Given this list of marker genes MET, AQP5, EGF, HGF, AQP3, EXOC4, STX4, CTNND1, NECTIN2, CYFIP2, CAMSAP3, EFNA1, EXOC3, EGFR, CDH1 (NCBI Gene Id 999), MYL2, NCKAP1, ABI1, MGAT3, RHOA, AFDN, EPHA2, ARF6, ENAH, NCK1, LPP (LIM domain containing preferred translocation partner in lipoma), ACTN1, DIAPH1, CTNNB1, KIFC3, VCL, PIP5K1C, IGF1R, VASP, MYO6, GIT1, ZYX, ROCK1, CTNNA1, LIMA1, PLEKHA7, here is a description of the gene set: from publication Schaefer CF, Anthony K, Krupa S, Buchoff J, Day M, Hannay T, Buetow KH (PMID 18832364) Human Gene Set: PID_ECADHERIN_STABILIZATION_PATHWAY studied in species Homo sapiens Stabilization and expansion of the E-cadherin adherens junction